The following is a description of a gene set: Human Gene Set: HP_ABNORMAL_ANKLE_PHYSIOLOGY studied in species Homo sapiens A functional anomaly of the ankle. Abnormal ankle physiology, and this is the list of marker genes: ANO10, SELENOI, SPTBN2, CCDC88C, KIF1A, STUB1, GLI3 (GLI family zinc finger 3), AARS1, CD40LG, MFN2, ERLIN1 (ER lipid raft associated 1), CYP27A1, TCEAL1, SCO2, HTT, REEP1, PEX16, SOD1, COMP, COL6A1, SLC16A2, FA2H, FGF13, AHDC1, NDUFS8, SAMD9L, LMNA, GALC, ATP6AP2, GCSH, SMG9, VAC14, SPART, KPNA3, TIMM8A, PYCR2, COQ4, SPG11, UCHL1, MARS1, PIGT, GFM2, POU3F4, ATL1, CARS1, MAP3K7, KLC2, KIF5A, ADGRG1, SYNE1, FLNA, OCA2, PI4KA, VCP, SV2A, GBA2, NIPA1, RTN2, SLC52A3, UBE3A, PLA2G6, NFU1, SPAST (NCBI Gene Id 6683), SLC39A14, RAB18, KIF1C, ZMPSTE24 (NCBI Gene Id 10269), NT5C2, PSAP, CAPN1, SLC1A4, CYP7B1, ERLIN2, ABCD1